Given this list of marker genes Gbp9, Csmd2, Pif1, Gbp10, Nxpe3, Cntn5 (contactin 5), Tmem175, Pdia3, Lrrc7, Tpd52, Nr2c2, Rif1, Loxl3, Ythdf2, Serpina1a, Gbp6, Tacr1, Fndc7, 4930426D05Rik, Notch1, Ring1, Sh3bgrl2, Spock1, Sh3d19, Mustn1 (NCBI Gene Id 66175), Vps35, Fgf1, Glce, Sfmbt1, Csnk1g1 (NCBI Gene Id 71616), H1f0, Zmym4, Slitrk4, Capn11, Heph, Rnf152, Hand2, Hipk2, Adamts5, Sgsh, Efr3b (NCBI Gene Id 668212), Slc24a2, Gypa, Pde4c, Pard3b, Tsc22d1, Kmo, Phyh, Neo1, Zfp462, Lmtk2, Pmfbp1, Pdxk, Epb41l5, Kif5b, Dhx32, Homer1, Rgs5, Pbx2, Npy1r, Ttc14, Gria4, Saysd1, Raph1, Cnnm3, Itgb3 (NCBI Gene Id 268495), Foxp4, Rasa3, Ubn1, Bicd2, Car4, Ccnc, here is a description of the gene set: studied in species Mus musculus Genes predicted to be targets of miRBase v22 microRNA mmu_miR_877_3p in miRDB v6.0 with MirTarget v4 prediction scores > 80 (high confidence targets). Mouse Gene Set: MIR_877_3P from publication Chen Y, Wang X (PMID 31504780)